Given this list of marker genes CUEDC1, DNAI2, EYA1, SSPN, ANK3, PDXDC1, HLA-DQB1, ENTPD1, ACADL, SLC4A8, CPT1A, C1GALT1, MTDH, KIF5B, D2HGDH, TRIM5, CPNE9, ACP5, BHLHE41, TCEAL9, PHKA1, TMEM254, ACAD10, TNK2, LSM8, CENPC, CITED2, G6PD, TGFBRAP1, CCDC126, SLC44A1, CDK5RAP1, RNF157, PCTP, CPEB2, TAF4B, ESCO1 (establishment of sister chromatid cohesion N-acetyltransferase 1), MPZL2, IRAK4, POMT1, here is a description of the gene set: Human Gene Set: BREDEMEYER_RAG_SIGNALING_VIA_ATM_NOT_VIA_NFKB_DN from publication Bredemeyer AL, Helmink BA, Innes CL, Calderon B, McGinnis LM, Mahowald GK, Gapud EJ, Walker LM, Collins JB, Weaver BK, Mandik-Nayak L, Schreiber RD, Allen PM, May MJ, Paules RS, Bassing CH, Sleckman BP (PMID 18849970) studied in species Mus musculus Genes down-regulated in pre B lymphocyte after induction of physiological DNA double-strand breaks (DSB) by RAG2; the changes depend on ATM but not NFKB signaling. DNA double-strand breaks are generated by genotoxic agents and by cellular endonucleases as intermediates of several important physiological processes. The cellular response to genotoxic DNA breaks includes the activation of transcriptional programs known primarily to regulate cell-cycle checkpoints and cell survival. DNA double-strand breaks are generated in all developing lymphocytes during the assembly of antigen receptor genes, a process that is essential for normal lymphocyte development. Here we show that in murine lymphocytes these physiological DNA breaks activate a broad transcriptional program. This program transcends the canonical DNA double-strand break response and includes many genes that regulate diverse cellular processes important for lymphocyte development. Moreover, the expression of several of these genes is regulated similarly in response to genotoxic DNA damage. Thus, physiological DNA double-strand breaks provide cues that can regulate cell-type-specific processes not directly involved in maintaining the integrity of the genome, and genotoxic DNA breaks could disrupt normal cellular functions by corrupting these processes.